Given this list of marker genes PADI2, ERCC3, NFKBIA, L3MBTL3, MED10, TFB2M, PAAF1, THRA, TAF12, SMARCB1, MED24, MED20, TAF6, APOBEC2, INTS12, ERCC6, ATF2, JUN, E2F3, GTF2A2, INTS8, TAF1C, MED11, TAF4B, TAF11L3, TFAM (transcription factor A, mitochondrial), GTF2H2 (NCBI Gene Id 2966), AICDA, INTS14, TAF8, GTF3C5, KDM1B (NCBI Gene Id 254751), E2F2, SUB1, VPS72, TAF1, POLR1G, SAMD1, PPP2CA, GTF2E2, MNAT1, OGG1, BDP1, MED30, KAT7 (NCBI Gene Id 63437), DHX36, GTF2B, ELOA, TAF11L10 (NCBI Gene Id 112488738), CEBPA, TAF9B, GLYR1, INTS3, WNT10B, MED4, MED13 (NCBI Gene Id 9969), POLR2I, RRN3P1, HNF1B, NFKB1, TAF10, GTF3C1, TWIST1, POLR2D (RNA polymerase II subunit D), MACROH2A1, EGR1, UBTFL6, ATAD2, TAF11L4, CREB1, NFKBIZ, HEY2, GTF2A1, RBM14, ATAD2B, TAF13, RSF1, WBP2, XPA, PPARGC1A, PWWP2A, INTS4, SETX, ARMC5, INTS6, GTF3C4, GTF2F1, MED18, PPP2R1A, TET3, CAVIN1 (NCBI Gene Id 284119), ZMPSTE24, TP53, TAF1L, MED6, MED31, TBP, MED23, APOBEC1, ASH2L, INTS10, INTS2, MORC1, INTS15, SIRT7, TAF11L11, ESR1 (NCBI Gene Id 2099), RBX1, TFB1M, INTS1, MAZ, N6AMT1, TTF1, CDK7, RRN3, MEN1, MED28, NAT14, SMARCA4, TBPL2, NCOA6, NKX2-5, GTF2A1L, UBTFL1, HNF1A, EP300 (NCBI Gene Id 2033), TAF7L, ELOC, APEX1, SPHK2 (NCBI Gene Id 56848), MED9, HMGB1, UBTF, GTF2H1, MED8, BAZ2A, TBPL1, MED25, MED29, ZNHIT1, FOXO1, INTS11, BRD7, MED17, MED21, PAXIP1, MED12, TRMT112, TAF11L7, ELOB, CCNH, SNAPC5, FOSL1, TAF11L2, RBBP5, CTCFL, POLR1E, MYC, RRN3P2, TAF11L12, APOBEC3A, INTS9, MITF, TAF11, MED26, KMT2A, MED27, CAND1, SMARCD1, POLR1F, MED14, TAF5, ERCC2, TAF11L13, ZNF451, CRCP, MED1, INTS7, GTF2E1, SMARCA5, TET1, APOBEC3F, INTS5, MED16, USP21, PRMT3, BRF2, TAF1B, ARID1A, CDK9, POLR3H, MED22, APOBEC3C, TAF11L8 (TATA-box binding protein associated factor 11 like 8), MED15, MED19, CDK4 (NCBI Gene Id 92978), TAF11L9, FAM47E, MYOCD, TAF3, TET2, GTF2H5, DR1, TAF7, ERCC1, PHF2, POLRMT, KAT8, TAF4, WDR5, BCLAF1, PPM1D, BRF1, TAF9, TAF11L14, SPI1, NOC2L, TAF6L, TAF11L6, KAT2B, SGF29, DPY30, ARID1B, CTNNBIP1, MED7 (mediator complex subunit 7), SRF, PSMC6, INTS13, GTF2F2, TAF2, POLR2G, KDM1A, here is a description of the gene set: studied in species Homo sapiens Human Gene Set: GOBP_DNA_TEMPLATED_TRANSCRIPTION_INITIATION The initial step of transcription, consisting of the assembly of the RNA polymerase preinitiation complex (PIC) at a gene promoter, as well as the formation of the first few bonds of the RNA transcript. Transcription initiation includes abortive initiation events, which occur when the first few nucleotides are repeatedly synthesized and then released, and ends when promoter clearance takes place.